The following is a description of a gene set: studied in species Mus musculus Catalysis of the posttranslational transfer of one or more glutamate residues to a specific residue on a target protein. Mouse Gene Set: GOMF_PROTEIN_GLUTAMIC_ACID_LIGASE_ACTIVITY, and this is the list of marker genes: Ttll9, Ttll4, Ttll13 (tubulin tyrosine ligase-like family, member 13), Tpgs1 (tubulin polyglutamylase complex subunit 1), Ttll2, Ttll7 (tubulin tyrosine ligase-like family, member 7), Ttll5, Ttll11, Ttll6, Ttll1